The following is a description of a gene set: Mouse Gene Set: GOBP_NUCLEOSIDE_MONOPHOSPHATE_METABOLIC_PROCESS The chemical reactions and pathways involving a nucleoside monophosphate, a compound consisting of a nucleobase linked to a deoxyribose or ribose sugar esterified with phosphate on the sugar. studied in species Mus musculus, and this is the list of marker genes: Gart, Rfk, Gmpr2, Ada, Adk, Impdh2, Ak5, Atic, Prps2, Pals2, Uck1, Slc29a1, Ampd1 (NCBI Gene Id 99676, adenosine monophosphate deaminase 1), Cda, Ampd3, Nt5c, Nt5c3, Adss1, Impdh1, Ak1, Pfas, Cmpk1, Dck, Tk2, Tymp (NCBI Gene Id 72962), Nme1, Ak3, Ak7, Gmps, Ppat, Dpys, Guk1, Adss2, Entpd8, Nt5e, Aprt, Dhodh, Cmpk2, Ak2, Pnp, Pals1 (NCBI Gene Id 70703), Uox, Dpyd, Ak8, Dut, Tk1, Uck2, Nt5c1a, Prps1, Dhfr, Ampd2, Nme3, Upb1, Cad, Adsl, Urah, Urad, Dguok, Umps, Upp2, Hprt1, Gmpr, Upp1, Ak4, Gda, Nt5c2, Dnph1, Nme2, Entpd1, Dctd, Nt5c1b, Nudt2, Paics, Shmt2, Tyms, Xdh, Uprt, Nt5m, Uckl1, Shmt1, Dtymk, Ak6